The following is a description of a gene set: studied in species Homo sapiens A highly soluble, elongated protein complex found in blood plasma and involved in clot formation. It is converted into fibrin monomer by the action of thrombin. In the mouse, fibrinogen is a hexamer, 46 nm long and 9 nm maximal diameter, containing two sets of nonidentical chains (alpha, beta, and gamma) linked together by disulfide bonds. Human Gene Set: GOCC_FIBRINOGEN_COMPLEX, and this is the list of marker genes: FGG, FGA, FGL1, FGB, FGL2, FN1, SERPINF2, THBS1